The following is a description of a gene set: Mouse Gene Set: GOBP_CILIUM_ORGANIZATION species: Mus musculus A process that is carried out at the cellular level which results in the assembly, arrangement of constituent parts, or disassembly of a cilium, a specialized eukaryotic organelle that consists of a filiform extrusion of the cell surface. Each cilium is bounded by an extrusion of the cytoplasmic membrane, and contains a regular longitudinal array of microtubules, anchored basally in a centriole., and this is the list of marker genes: Odf2l, Mphosph9, Cyld, Tctn2, Avil, Rp1, Tchp, Kcnj10, Rabl2, Neurl1a, Csnk1d, Iqub, Arl3, Atg3, Kctd17, Nme8, Lima1, Cfap91, Cfap65, Rpgr, Dnhd1, Nectin2, Lama5, Rsph1, Cep41, 2700049A03Rik, Ccdc146, Pibf1, Spag17, Usp9x, Rsph4a, Cep70, Tekt4, Lrrc46, Dzip1, Intu, Spag16, Ttc39c, Ehd3, Plk4, Ccdc159, Ift80, Ccdc65, Tmem107, Gdi2, Pierce2, Arhgap35, Atp6v0d1, Dnaaf1, Iqcb1, Dusp23, Rab34, Tsga10ip, Clcn4, Rpgrip1, Ttll5, Wrap73, Septin2, Kif19a, Htt, Rp1l1, Inpp5e, Ccdc103, Wwtr1, Fam161b, Ubxn10, Ssna1, B9d1, Tmem237, Vdac3, Dnaaf10, Meig1, Foxj1, Cfap221, Parva, Ccp110, Tekt1 (tektin 1), Fhdc1, Cep250 (NCBI Gene Id 99368), Pla2g3, Dnaaf3 (NCBI Gene Id 436022), Kif3b, Cep89, Saxo1, Cby1, Cfap73, Pfn4, Tctn1, Cep135, Ccdc42, Mir34c, Onecut1, Kcnf1, Actr2, Fam161a, Dnai2, Cplane1, Syne1, Ift46, Pcm1, Mark4, Fbxw8, Spef1, Ttc21b, Arl6, Cep128, Ccdc96, Ocrl, Kif27, Rrp7a, Ablim3, Ccdc15, Fnbp1l, Alms1, Nudcd3, Dynlt2b, Dtnbp1, Mapre1, Onecut2, Ofd1, Kifap3, Septin9, Ttc21a, Rilpl2, Dnai4, Dnah7c, Fam149b, Arl13a, Dzip1l, Catip, Cep162, Rfx4, Cdc14b, Gsn, Odad4, Odad1, Snx10, Ift88, Tbc1d30, Ttll1, Ift70a2, Cfap58, Lca5, Cep120, Wdr11, Ropn1 (NCBI Gene Id 81026), Ift27, Dnm2, E2f4 (NCBI Gene Id 72062), BC048507, Tctn3, Rab17, Bloc1s6, Crocc, Mir449b, Cep19, Atmin (ATM interactor), Elmod1, Cfap100, Enkd1, Nphp3, Ccdc13, Cfap97d1, Celsr3, Cc2d2a, Tapt1, Pkhd1, Traf3ip1, Luzp1, Tmem216, Disc1, Micall1, Pcdh15, Lrrc23, Cfap206, Cfap54, Ccdc39, Cfap47, Fsip2, Spag1, Rab23 (NCBI Gene Id 98704), Prickle1, Ccdc113, Aurka, Dnaaf6rt, Ift25, Flna, Odf2, Dnaaf2, Ccdc38, Ttbk2, Cenpj, Ift57, Ulk4, Tbc1d7, Cfap161, Ablim1, Fuz, Vangl2, Cep97, Drc1, Spata6, Rabep2, Ttc12, Dnaaf4, Elmod3, Dnah1, Ptpn23, Fsip1, Macir, Ehd2, Bbs10, Dnah5, Bbs1, Noto, Ak7, Atxn10 (ataxin 10), Nedd9, Mns1, Yap1, Unc119b, Dnaaf11, Cfap61, B3glct, Mir449a, Daw1, Arl13b, Ttc17, Bbs9, Wdr90, Dctn1, Kif24, Tbc1d21, Alpk1, Akt1, Cfap74, Spaca9 (NCBI Gene Id 69987), Kif17, Syne2, Stil, Lca5l, Cplane2, Mcidas, Bbof1, Mir129-2, Ccdc88c, Drc7, Clxn (NCBI Gene Id 74659), Dnah17, Ube2b, Exoc5, Cfap298, Wdr44, Cep290, Rilp, Ift70a1, Nme5, Spef2, Cilk1, Ift122, Armc2, Celsr2, Ccno, Cep164, Ccdc28b, Ttll8, Gfy, Ift20, Zmynd10, Cibar1, Ccdc66, Galnt11, Arf4, Ift70b, Ccdc63, Odad2, Tmem80, Bbs2, Cimap3, Mapk15, Cep350, Mak, Mkks, Cfap410, Odad3, Wdr19, Zfp423, Cfap20, Bbs4, Ift56, Rab8a (RAB8A, member RAS oncogene family), Tmem231, Mir34b, Dnali1, Tmem17, Bbip1, 1700012B09Rik, Spag6l, Rpgrip1l, Gsk3b, Dynll1, Dcx, Pkd2, Dync2i2, Dync2h1, Septin7, Cep83, Ppp1r35, Cep131, Asap1, Ttll3, Ssx2ip, Rilpl1, Ift172, Dnah8, Ro60, Cep126, Kif3a, Dnaaf6, Zic2, Akap4, Eno4, Sclt1, 4933427D14Rik, Cfap44, Rfx3, Misfa, Txndc15, Rfx2, Lpar1, Dnah2, Cc2d2b (NCBI Gene Id 676937), Ahi1, Ccdc32, Gmnc, Ccdc40, Rsph9, Marchf7, Cfap126, Pqbp1, Fbf1, Dnal1, Actr3, Zmynd12, Armc12, Ehd1, Rab11fip3, Ccdc88a, Tmem138, Ift43, Lrguk, Gas8, Cdc14a, Ift81, Lrrc61 (NCBI Gene Id 243371), Pcnt, Tekt2, Cibar2, Bbs7 (NCBI Gene Id 71492), Bbs12, Atg5, Cfap69, Ift22, Hdac6, Cfap157, Pierce1, Armc9, Dnaaf5, Cep78, Cfap53, Cwh43, Iqcg, Ehd4, Map4, Erich3, Iqcn, Gorab, Ift140, Cluap1, Atp6v1d, Tub, Tekt5, Dcdc2a, Ccdc57, Trappc14, Notch1, Dnai3, Tesk1, Wdr35, Ptpdc1, Hap1, Ift52, Jhy, C2cd3, Yif1b (NCBI Gene Id 77254), Dnah7a, Spag6, Rttn, Rsph6a, Gk2, Ttc8, Bbs5, Rab11a, Cfap70, Cdkl1, Trim32, Dnmbp, Mir449c, Rab29, Cabcoco1, Ift74, Togaram1, Tbc1d31, B9d2, Ttc29, Adamts16, Cntrob, Nme7, Tekt3, Dync2li1, Dnajb13, Kcnq1, Hydin, Nek1, Rab3ip, Dnai1, Sdccag8, Dnah7b, Cdkl5, Tmem67, Poc1a, Snap29 (synaptosomal-associated protein 29), Pdcl2, Mks1, Dync2i1, Hyls1, Limk2, Cfap43, Entr1, Klc3, Hoatz, Abcc4, Cdk10 (cyclin dependent kinase 10), Cfap119, Cfap57, Fbxo24, Evi5l, Poc1b, Cep20, Tbc1d32, Tpgs1, Stk36, Wdpcp, Nherf1